Given this list of marker genes RPL38 (NCBI Gene Id 6169), ATP6V1B1, TCAP, HOXA3, PDGFRA, DVL2, ATP8A2, CFC1B, SPARC, CUL3, INHBA, HIF1A, AMOT, HS2ST1, ITGAV, NEUROG1, HOXB1, YTHDF2, TBX5 (NCBI Gene Id 6910), DLX2, MYC, LIAS, MAPK1, MMP9, SMAD4, MSGN1, SETDB2, PFN1 (NCBI Gene Id 5216), PRKRA, LRP5, FRAS1, INSIG2, BCL2L11, NKX3-2, SPRY2, MAPK7, ACVR2A, GBX2, FZD3, SOX17, RBPMS2, IFT140, COL2A1, HOXD10, TBX20, ETS2, COL7A1, PTCH1, CYP26B1, CTR9, HES1, NTN1 (netrin 1), FOXL2 (forkhead box L2), ETV2, SKI, HOXC9, CC2D2A, MYO15A, REST, MSX2, TAL1, TTBK2, CCDC40, PLS1, ACVR1, MED1, PITX1, CLRN1, RARG, VASP, MMP15, MYADM (NCBI Gene Id 91663), PTK7, DLL4, PAX5, FBN2, NR4A3, FGFR1, BRD2, EYA2, ALDH1A2, CCDC103, CER1, DUSP2 (NCBI Gene Id 1844), BRD3, IFT122, EXT2, HMGA2, TBX15, MEGF8, CRYAA, SMO, GLMN, STOX1, SIX3, RBP4, WNT3, HOXB2, MFAP5, MYO3A, BMI1, HMX3, GRSF1, JAG2, BBS7, GRHL3, RARA, DLD, HOXB4, ITGB5, SDC4, NECTIN3, BCL10, MAPK3, NOTCH1, PITX2, MYH3, MMP2, IFT57, TGFB1, LUZP1, POU3F4, MMP8, APLN, USH1G, SETD2, WNT16, OSR1, TBXT, PRKAR1A, CHD7, NODAL, BBS4, WNT5B, TMIE (transmembrane inner ear), MKKS (NCBI Gene Id 8195), ECE1, SUFU, DUSP5, GDF3, EYA1, PBX1, NAT8B, SNAI1, TRIOBP, ABL1, ADIPOQ, CDKN1C, PCGF2, TBX1, DYNC2H1, FOXC1, MESP2, CHRNA9, PRICKLE1, APOA1, LRIG1, ALX1, LEF1, TGFBR2, MICAL2, RDH10, ITGA7, CTNNB1, TGFB1I1, MTHFD1L, LBX2, FBN1, PALS1, HOXA1, FOXE1, CECR2, PPP1R35, LBX1, TH, MIR200C, SCX, TULP3, NDRG4, DVL1, FLVCR1, WNK1, POU5F1, STK3, LLGL2, ROCK2, FRS2 (fibroblast growth factor receptor substrate 2), GDF7, MAP3K20, BLOC1S5, TRIM15, HOXA5, DCANP1, DEAF1, SMAD2, INSIG1, HOXD11, KCNQ4, NIPBL, TCTN1, ZBTB17, HOXA13, CLRN2, SP8, TBX3, MAP2K5, SLC44A4, SPECC1L, TGIF1, CTHRC1, ID2, HOXA10, FGF8, KLF4, FGF4, DACT1, WDR19, TWIST1, STIL, SIX2, DLC1, GNA12, TEAD2, HOXD12, ATOH1, GATA3, HOXA11, RBM14, NCKAP1, MKS1, FGF9, HPN, STRA6 (NCBI Gene Id 64220), TSHZ1, LAMA3, ITGB4, ALDH1A3, COL4A2, SYF2, SOD1, ZEB2, OTX1, SPINT2, WNT8B, LHX1, GPI, GREM1, MED12, LAMA5, HES5, GJB6, IFT52, GLI2, PLPP3, TRIM28, HDAC2, ST14, SOBP, RSPO3, LHX2, TBX6, HIPK2, ZNF568, ELF5, LAMB1, LDB1, IRX2, BMP4, GPC3, ACD, IHH, IRX5, NEUROD1, ENSG00000285205 (novel transcript), GREM2, WNT9B, WDR83, LATS1, LRP4, RACK1, PRKACB, EPHB2, HOXC10, EDN1, MYO7A, OSR2, LRIG3, EPHA2, BBS5, PRKACA, GRXCR1, MFAP2, TMED2, SLITRK6, YBX1, DUSP1, TRAF6, C2orf49, SALL4, RTF1, VEGFC, NCOA1, SUPT20H, MIR221, ZNF281, NF2, ITGA2, APLNR, COL6A1, WNT3A, RNF2, BPNT2, FOXG1, HYAL1, COBL (cordon-bleu WH2 repeat protein), NKX2-5, KAT2A, GATA6, PSEN1, COL11A1, SEC24B, TSC2, HOXD3, TMEM107, NHERF1, INTU, CLUAP1, POGLUT1, ZNF358, MIXL1, ITGB2, KIF16B, GLI3, EXOC4, HOXC11, RIC8A, CACNA1C, EFEMP1, PBX2, CITED2, SLC39A3, SOX9, NANOG, SHOX2, BMPR2, PAX6, TASOR, LRP2, WNT6, RYR2, EPB41L5, ARMC5, DLX5 (distal-less homeobox 5), CHRNA10, KDM2B, MBP, PKD2, SOX2, SOX7, GRB2, ANKRD24, NOTO, DLL1, DLX6, MSX1, FRZB, HOXA4, MIR1-1, TGFBR1, EN1 (NCBI Gene Id 2019), RECK, WNT7A, STRC, SFRP1, ARHGAP35, FREM2, MTHFR, SOS1, RET, LHFPL5, OTOP1, FLT1, MTHFD1, BMPR1A, CRABP2, MOSMO, SEMA4C, NAGLU, ITGA4, RARB, WHRN, SP3 (Sp3 transcription factor), HOXA9, COL12A1, HMX2, PHACTR4, CDH23, FN1, COL8A1, OTX2 (NCBI Gene Id 5015), HNF1B, CCDC39, HOXB3, SOX8 (SRY-box transcription factor 8), GJB5, ATOH8, FOXH1, OPA1, IGF2, OVOL2, LNPK, WNT7B, HIRA, AR, ZBTB16, FZD7, SHH, ITGA5, AFF3, APAF1, ALX3, TBX19, SULF1, DNAAF1, FZD2, FGF10, FOXA2, MMP14, RSPO2, ITGA3, YAP1, LMBR1, MYH9, SPINT1, ITGA8, ACVR2B, MMP16, FGF2, FOXI1, PROX1, FZD6, MYF5, IL10, HOXD4, TRAF3IP1, HOXB9, GATA4, ROCK1, ENG, HTR2B, CREBBP, AHI1, GJA1, RNF207, LMBRD1, PAX2, OFD1, SIX1, FOLR1, KDF1, TGFB2, CELSR1, EOMES, MESP1, RALA, CEP290, CFC1 (cryptic, EGF-CFC family member 1), HIPK1, BAX, HSBP1, CFL1 (NCBI Gene Id 1072), MBNL1, VANGL2, TBX2, BMP5, SOCS3, STK4, ARFRP1, BCR, COL5A2, NDST1, SLC39A1, HDAC1, TBX18, TWSG1, PCDH8, PAX8, ITGB1, MYO6 (myosin VI), ZEB1, GJA5, ADM (NCBI Gene Id 133), VAX2, TCF21, WNT5A, NUP50, MAFB, WDPCP (NCBI Gene Id 51057), WNT2, IL1RN, FOXF1, HOXB8, TFAP2A, SATB2, WNT1 (Wnt family member 1), DKK1, FLRT3, ZFP36L1, COL5A1, FBXW4, AHDC1, TRIM71, PDZD7, GDF5, WNT4, MIR145, FUZ, DNAJB6, PDX1, ZIC3, DSCAML1, WNT2B, HOXD9, KIF20B, FOXF2, NR0B1, GDNF, HOXB6, FGFR2, SRF, SLC39A12, KDM6B, TAF10, GATA2, SIX4 (SIX homeobox 4), PAF1, TECTA, HOXC4, EFNA1, CDC73, HESX1, UGDH, TSC1, MAP2K1, HAND2, RGMA, MAB21L2, MDFI, CDON, DUSP4, BMP7, HLX, RPGRIP1L, NOTCH2, HOXB7, POFUT2, FOXC2, EXT1, RPS7, IFT172, SCRIB, MUSTN1, TPRN, DYNC2I1, VTN, GRHL2, USH1C, CCN1, SOX11, MACROH2A1, ARL13B, SMAD3, RAC1, TBC1D32, ITGB3, C2CD3, GRXCR2, POU4F3, ZIC1, SFRP2, TIFAB, CASP3, PLXNB2, DLG1, CDK20, GSC, MEF2C, LMO4, ASB2, NOG, RUNX2, HAND1, MYCN, HOXD13, FZD5, EIF4A3, HNF4A, LAMB3, LEO1, TP63, WLS, PRRX1, TGIF2, TMEM231, CRB2, NPHP3, HOXA2, TENM4, SP9, TXNRD1, B9D1, GLI1, IRX3, HOXA7, TBX4 (NCBI Gene Id 9496), HOXB5, LATS2, SALL1, TP53, GCM1, AXIN1, MIB1, APELA, SMAD1, WNT11, MYO3B, CHST11, NECTIN1, TLX2, ALX4, FOXN4, EDNRA, KCNQ1, MIR150, TTC39C, IRX1, SOX18, here is a description of the gene set: The process in which anatomical structures are generated and organized during the embryonic phase. The embryonic phase begins with zygote formation. The end of the embryonic phase is organism-specific. For example, it would be at birth for mammals, larval hatching for insects and seed dormancy in plants. Human Gene Set: GOBP_EMBRYONIC_MORPHOGENESIS species: Homo sapiens